Given this list of marker genes UBE2A, PHACTR2, ARHGAP42, AKTIP, AHSA2P, KPNA6, MME, SLC2A13, HDAC2, PLK4, DMTF1, BBS12, ISCU, ARHGAP32, PHAX, BORCS7, CDR2L (NCBI Gene Id 30850), NPAP1, SLC16A12, RAB3B, STRIP1, SOBP, RPGRIP1L (NCBI Gene Id 23322), CENPS, EYS, TMEM19, KCNIP4, MCUR1, CNST, CAPRIN1, MATN2, ASH1L, TARP, MDM1 (Mdm1 nuclear protein), GRIP2, CALCR, ZNF106, COL4A4, API5, LRRTM2, CREB5, CNTN1 (NCBI Gene Id 1272), ETF1, RIF1, TNPO1, VEZF1, SPRY3, MIB1, ZNF570, CD55, LHX9, PLXDC2, GPC6, CDCA2, RNF13, CELF5, PF4V1, ERBIN, SLC24A2, FICD (NCBI Gene Id 11153), EPM2AIP1, FERMT2, RALGAPA2, RBMX, ZNF480, FBXO28, TRABD2A, TFDP2, OTP, ERCC4, FAM161A, NUP50, RIPOR1, KIF26A, GCA, ETFRF1, FAM83B, PHF14 (PHD finger protein 14), JADE1, ARL6IP6, CHEK1, PTPN5, SNX1, LIN28B, ACOT12, KIAA1143, PYM1 (NCBI Gene Id 84305), FAM110B, PHEX, KLF5, KIF1B, ZNF329, RBM41 (NCBI Gene Id 80171), FCRL4, CELA1, RALGDS, TAOK3, ZNHIT3, CWC27, FXN, CPSF6, MED13, CCDC59, ZCWPW2, GTF3C4, SPIRE1, WNT5A, EPG5, ARPC5, PIEZO2, CNTN5, ARHGAP25, GUCY1A2, MEDAG, CPEB2, BICRAL, DAZL (deleted in azoospermia like), FMR1, CACYBP, PIGT, OTX1, KLHL28, QDPR, LPGAT1, TIPARP, VPS13A, PTPN12 (protein tyrosine phosphatase non-receptor type 12), SELENOI, FLT1, SYT14, ABTB3, NAALADL2, ARB2A, VGLL3, XKR6, A1CF, GPR183, KLHL32, MTURN, CER1, EPN2, POU3F2, NRG2, EP300, SETX, OVOL2, OTX2, ADARB2, TMED4, TPD52L3 (TPD52 like 3), PLXNA2, XPO1, TRAF3IP1, ZNF366, PTMA, TIGAR, DIP2B, SOX4, MBNL3, SETMAR, EIF3B, FBXL3, COQ10B, TMCC1, PPP1R3B, MINDY2, COCH, ZDHHC23, VXN, PCSK2, ARID3A, SERINC3, NAB1, SCN8A, PLCXD3, ANGPTL1, GAN, IGF1, IL17A, ABCA5, SORBS1, PHF6 (PHD finger protein 6), ALDH1L2, METTL8, UBE4B, MXI1, SPATA13, TRIM5, CACNG2, ZBTB34, DSG3, RCOR3, FAT3, PHLDB2, GABRB3, CXCL6, C8orf44-SGK3, GYPA, RPS6KB1, SH3KBP1, CENPP, ATP9A, PIGBOS1, NRXN1, NEGR1, ILDR2, LMNA, RAB23, PLPPR4 (phospholipid phosphatase related 4), STXBP5, BTLA (B and T lymphocyte associated), NEDD4L, UGT2B15, TFB1M, TMPO, C18orf63, IVD, PRKAA2, CISD1, CUL4B, DALRD3, TMOD2, SLC35F1, CEP97, CAAP1, RGS17, CFAP68, KCNMB2, PDZRN4, SNAPC3, RCC2, SPOCK3, TET1, SMAD9, ICA1L, RAB39A, ZCCHC9 (NCBI Gene Id 84240), KDM4C, LYSMD3, PIK3R1, COL14A1, ETV1, AMMECR1, G3BP1, FAM120C, TMEM215, TTC17, TMPRSS11E, BCL11B, CEP120, RPF1, RNF125, RAB30, MPP7, PCDH19, INO80D (NCBI Gene Id 54891), PPM1L, EMP1, AIPL1, FAM20B, GLUL, ABCE1, MAP2, NEXMIF, SGK3, ZDHHC21, IRX3, TBC1D8B, PTPRT, TNRC6A, SLC15A5, NIPSNAP3B, LOXHD1, EPHA5, LPAR4, DCUN1D5, MAP3K20, CAB39, C6orf47, SRPK1, ASPN, SCARA5, KCNB1, BMPR2, YTHDF3, B3GNT3, CHL1, FGF12, GBP7, CDC42SE1, ABLIM1, SHISA9, DENND1B, TRGC1, SCN1A, PICALM, ATF7IP, C1QTNF7, PAPOLB, KCNQ5, CFLAR, LRBA, CCDC86, C11orf71, FBXO30, BRD3, CAST, ZNF138, NSD3, SLC48A1, MED6, C1orf21, TBC1D24, OPRM1, HMGA2, ITGA4, FAM81B, CADM2, BLZF1 (basic leucine zipper nuclear factor 1), AGGF1, ZNF345, SPAG1, HDGFL3, PRDM6, RAPGEF4, SLC16A9, ARHGEF10L, MACO1, CDS1, SESTD1, EFEMP1, CSNK1G1, HORMAD1, RNF207, PCDH7, CNTNAP2, GABRG1, MEPE, MED30, EDNRB, PTN, BCL6, WDSUB1, BCKDHB, SPAG9, SPMIP8, CREB3L1, LIMCH1, AEBP2, MARVELD3, CDIN1, PTPN4, PUM2, GRPEL2, ZNF587, TTC28, ZNF197, ZNF704, PKD2, SAMD4A, THAP12, NAA30, FZD10, DPYSL2, ZNF280D, AFAP1L2, TMED6, STK39 (NCBI Gene Id 27347), SLC25A46, GXYLT1, PROX1, PRPF4, GAPVD1, RETREG1, HDAC9 (NCBI Gene Id 9734), NDST3, DNM3, MYT1, SLC25A24, MAPRE1, GSK3B, CAMK4, EGR3, RRAGD, GUF1, CDC73, ACOT13, HOOK3, NFATC3, CLOCK, IKZF2, SIX3, C2orf88, DUSP19, MLXIPL, NPEPPS, BNIP3, LAMC1, TLCD4, KIAA1210, TENT2, AHDC1, TRIM2, PTPN14, MFSD4A, CTNNA2, LMBR1, ZCCHC14, CEPT1, here is a description of the gene set: from publication Chen Y, Wang X (PMID 31504780) Genes predicted to be targets of miRBase v22 microRNA hsa-miR-6885-3p in miRDB v6.0 with MirTarget v4 prediction scores > 80 (high confidence targets). species: Homo sapiens Human Gene Set: MIR6885_3P